Given this list of marker genes Itga6, Fn1, Itgb1, Sdc3, Tgfb1, Sdc2, Itgav, Itgb3, Sdc1, Vtn, Fgf2, Itgb4, Itga2, Sdc4, here is a description of the gene set: studied in species Mus musculus Syndecan interactions Mouse Gene Set: REACTOME_SYNDECAN_INTERACTIONS